Given this list of marker genes SART3, PLAT, SLC9B2, ZNF324, TRIM48, TRIM31, DAD1, NLGN1, CUL5, SRP68, EDNRB, SPMIP8, TRMT10C, FAM199X (family with sequence similarity 199, X-linked), CIZ1, JAM3, NDUFB11, TMEM225B, CRHR2, ANXA5, KLF17, SERBP1, LAMTOR5, PRSS16, TGM1, SRPX2, PRKCH, ZSCAN20, HNRNPD, THPO, GPX8, MAP1B, BLOC1S4, DNMT3B, ZNF229, GPR83 (G protein-coupled receptor 83), CDH11, AKT3, OPRK1, SFTA2, ATP5MC2, SUGT1, AGA-DT, PTMS, SIK3, MKLN1, NPPA, CCNYL2, NRIP2, KCNE2, LRRC25, FAM228A, MYDGF, CPD, C17orf100, RPS15, EDN3, MIPOL1, TCEANC2, SUV39H2, MTNR1B, F8, MRPS33, SAR1B, CDH19, PCGEM1, PPP1R7, NDST4, CPA4, CALCRL, AHCYL1, UCMA, SREBF2, CSNK2A2, TENM1, NHEG1, CIMIP6, CFAP126, ZXDB, EDNRB-AS1, AGO3, FRG2EP, CYP4B1, GJA10, EBF2, RPS14, LYSET, SLC7A6OS, GARS1-DT, ZNF277, PDIA3, EQTN, POF1B, DHX38, BNIP1, MMP27, BAZ2A, NPIPB3, HSP90B1, PLXNC1, HYAL1, FBXO45, LINC01692, APPL2, ARHGAP5-AS1, AIFM1, ADORA2B, USP12, KIF2B, UPK1B, ADAM12, TOB1, LINC00307, ZBTB37, EXOSC3, KIZ, TAF1A, CUTC, HSPA12A, GUCD1, RCHY1, DOC2B, LCA5L, C5orf22, TRAK2, LAX1, HCG11, RANBP10, DOCK5, EPRS1, MAP2K4, HAGLR, RP1L1, KRTAP1-3, GPR63, VPS37A, KCNG3, FOXE3, MIR646HG, GNAI3, CLDN1, PCDHB16, SLC2A10, ARSL, CYP8B1, PHKA1 (NCBI Gene Id 5255), SUMO2, CAPZA3, DNAJB11, LYAR, PIEZO2, CSN2, LINC00919, BRCA2, PAG1, BRF2, CATSPERB, RNF6, DDX27, NDUFS4, RBBP9, BSN, DYNC2I2, TACO1, GREM2, MRTFA, ZNF582, PIMREG, UQCRB, CNTN3, RPS10P7, AGTRAP, TIMM22, HDX, HEMGN, EPHB6, CCDC87, UCA1, TUBG1, RABEP1, CSN1S2AP, MSI1, CT83, OR1A1, TIE1, FAM118B, ENTREP1, KIN, OOSP2, here is a description of the gene set: Human Gene Set: GSE34156_UNTREATED_VS_6H_NOD2_AND_TLR1_TLR2_LIGAND_TREATED_MONOCYTE_UP from publication Schenk M, Krutzik SR, Sieling PA, Lee DJ, Teles RM, Ochoa MT, Komisopoulou E, Sarno EN, Rea TH, Graeber TG, Kim S, Cheng G, Modlin RL (PMID 22447076) Genes up-regulated in monocytes (6h): untreated versus muramyl dipeptide andM. tuberculosis 19 kDa lipopeptide. species: Homo sapiens human blood monocytes were isolated, activated and harvested at several timepoints In this study, we identified genes that were differentially expressed in human monocytes activated with eiter NOD2L and/or TLR2/1L.